The following is a description of a gene set: from publication Zhou Q, Amar S (PMID 18025224) Porphyromonas gingivalis (P. gingivalis) can trigger an inflammatory condition leading to the destruction of periodontal tissues. However P. gingivalis LPS and its fimbriae (FimA) play different roles compared with the live bacteria in the context of intracellular molecule induction and cytokine secretion. To elucidate whether this difference results from different signaling pathways in host immune response to P. gingivalis, its LPS, or its FimA, we examined gene expression profile of human macrophages exposed to P. gingivalis, its LPS, or its FimA. A comparison of gene expression resulted in the identification of three distinct groups of expressed genes. Furthermore, computer-assisted promoter analysis of a subset of each group of differentially regulated genes revealed four putative transcriptional regulation models that associate with transcription factors NFkappaB, IRF7, and KLF4. Using gene knockout mice and siRNA to silence mouse genes, we showed that both TLR2 and TLR7 are essential for the induction of NFkappaB-containing genes and NFkappaB-IFN-sensitive response element (ISRE) cocontaining genes by either P. gingivalis or its purified components. The gene induction via either TLR2 or TLR7 is dependent on both MyD88 and p38 MAPK. However, the unique induction of IFN-beta by P. gingivalis LPS requires TLR7 and IFNalphabetaR cosignaling, and the induction of ISRE-containing gene is dependent on the activation of IFN-beta autocrine loop. Taken together, these data demonstrate that P. gingivalis and its components induce NFkappaB-containing genes through either TLR2- or TLR7-MyD88-p38 MAPK pathway, while P. gingivalis LPS uniquely induces ISRE-containing genes, which requires IFNalphabetaR signaling involving IRF7, KLF4, and pY701 STAT1. species: Homo sapiens Genes up-regulated in macrophages by P.gingivalis LPS (lipopolysaccharide). Human Gene Set: ZHOU_INFLAMMATORY_RESPONSE_LPS_UP, and this is the list of marker genes: IGF2-AS, SYCE1, RPS6KA5, MAGEE2, PML, PYY, LINC00630, DDR2, SLC28A1, DDX42, FZD1, IFIT3, ZC3H12A, LEF1, TM4SF18, GIPR, SCGB1D1, BTG2, RTP4, CCDC65, CGAS (cyclic GMP-AMP synthase), FFAR2, IRF8, ATP2B2, CTRB1, IRX5, ATP11C, KIF1B (NCBI Gene Id 57598), KREMEN1, STAT5A, APCDD1L-DT (NCBI Gene Id 149773), TRIM36, CXCL3, HPS4, SLC1A2, PLAAT5, HS3ST3B1, BCL11A, RAPGEF5, OAS3, STC2, NCOA7, KXD1, AGBL5, LDC1P, ENSG00000232995, NRL, AQP4, EPB41L5, EDN1, TMEM67, HOXB-AS3 (HOXB cluster antisense RNA 3), WTAP, CT47A11, IFIT2, ANGPTL1, SYDE1, SEMA6A, CDON, CBLB, AGBL1, NFKB2, ST7-AS1, KRTAP2-2, PTPN1, DAZ1, LDHAL6A, UBE2FP1, FRMD7, TMEM35A, NEFL, SLC2A11, IL23A, KRT36, CRACR2A, COBL, FGFR1OP2, CD80 (NCBI Gene Id 941), PALM2AKAP2 (PALM2 and AKAP2 fusion), CIMIP4, DYNC2H1, IL27, NPHP3-AS1, MAPK11, ALX3, ITGB8, GID8, ISG15, IFNL1, C4orf33, DMRTB1, WNK4, SLFN5, CSF3, AHNAK2, KLK10, RNF144B, ANKS6, NAMPT, FCAR, MIR600HG, NEDD4L, RBM34, SPON1, TBX20, AKAP1, CEMIP, HAGLROS, DCAF8, IRF7, FILIP1, TRIP10, IL12B, WNT5A, CCL20, KLF5, DRP2 (NCBI Gene Id 1821), CCRL2, KLHL41 (NCBI Gene Id 10324), SHD, ESCO2, ABCC11, FSCN1, CAMK1G, DUSP5, PNMA2, GEMIN7, CLEC12B, TPSD1, JRK (NCBI Gene Id 8629), KLF4, G0S2, GLYATL1, MXRA5, OXGR1, CCL4, OSM, CCL23, IGFBP3, ZBTB10, EGFLAM-AS2, CADPS, SDC4, NIPAL4 (NIPA like domain containing 4), HELZ2, AXDND1, CYP7A1, TLR2, USP18, ATP1B4, ANP32D, LINC01138, AFF4, ENSG00000241345, IER3, CD44, ADAMTS20, NINJ1, RPTN, SLC25A28, SCN2B, CCL18, ZC3H12C, USP12P1, SNTN, UPK2, RPE65, LIMK2, CYP3A7, SRC, DMRTC2, MAGEA5P, SGPP2, MBD3L2, TGIF2LX, RNF148, GPR135, MAPK4 (NCBI Gene Id 5596), TNF, FAM218A, CNBD2, LINC02762, SLC26A9, LIMS1, MPP3, HERC5, C1QC, OGFRP1, LINC01692, PLPP3 (phospholipid phosphatase 3), PNMA8A (NCBI Gene Id 55228), STMN4, CFAP65, ADAMTS5, EREG, TPD52, NEXN, ICAM1, NOX4, GPLD1, ATP2B1-AS1, PNLIPRP1, RAB39A, SIAE, MAFF, LITAF, RCN3, HAL, RAPGEF2, KIF25-AS1, RAB3B, MFSD2A, FOSL1, FUT4, SLC5A1, LINC02907, LINC00221, RORA-AS1, GH2, MCF2L, VWF, STBD1, C22orf15, MOB3A, OTUD7B, ELOVL7, SNAI1, CNTLN, SPEF2, ACOT6, ADM, RNF19B, CCL15, SOX21, BAMBI, IFIH1, AIPL1, MX2, CTNNA2, MORN1, NBN, PDXP-DT, MRI1, SIK3, ERG28, SULT1E1, LBX1-AS1, FCRL5, UPB1, OASL, MBL1P, TMPRSS6, PRICKLE2-AS3, LINC00837, ACOD1, DMRTA1, REL, NBR2, SYT9, B4GALT1, PNLIP, MAP2K3, SSTR2, EPB41, CCL8, CSRNP1, N4BP2L2, RAPH1, CREB5, IYD, S100A7A, BTBD9, CXCL9, OR7C1, NRAP, DDX3Y, VCX, ELF3, ACSL1, ZNF876P, ARL4D, NETO1, LINC02028, CATSPERG, OSR2, ADORA2A-AS1, RIPK1, SEMA6C, TP53INP2, TNFAIP2, SEC14L4, RAB6B, SRGAP1, CXCL1, HOXB1, SMAD4, CD55, PPP1R26-AS1, CATSPER2, IFNB1, RELA, GHRHR (growth hormone releasing hormone receptor), IL1R1, MYL2, FGF17, BRICD5, PDLIM5 (NCBI Gene Id 10611), KITLG, ENSG00000282408, TDRP, CXCL2, CA13, TEC, OAS2, IFI44, PPFIA2, DTX3, DENND5A, BCL2L1, NT5C3A, FOXP2, TP73, PTPN21, RELB, ZC3HAV1, BRINP1, ARHGAP31, KLHL14, PTGS2, CXCL10 (NCBI Gene Id 3627), CDH15, TTC9, USF3, MARCKS, DDX6, NPAS3, PTX3, ZNF815P, OAS1, IL18, RIGI (RNA sensor RIG-I), CDH19, CFAP69, TGM1, EOLA1-DT, NOX1, KRTAP2-4, CFTR, ZNFX1, NKAIN3, BRCA2, IFIT1, MIR3142HG, CDC42EP4, ZNF471, SNN, NLRP14, GFER, TIMM50, SLC28A2, HTT, IRF6, CAST, ADAM17 (ADAM metallopeptidase domain 17), CLDN1, SLC24A1, ADH1B, SLC19A4P, IL6, ABL2, GPC3, SERPINE1, IL1B, ATP2B1, PXDN, PLAUR, DNASE1L3, LAMA3, NKX3-1, DNAI7 (dynein axonemal intermediate chain 7), RDX (NCBI Gene Id 5962), LINC02372, SPATS2, SOCS1, GRIA1, DRAM1, RBBP6, TSLP, CH25H, GYS2, C11orf96, NFKB1, FZD4, ITGA9, JAG1, IRAK2, ZFX, SERPINB2, PPP1R15A, RPS2P45, TLR7, SNTG1, CYP2F1, SPSB1 (NCBI Gene Id 80176), HSPA1A, TNFSF9, GPR84